Given this list of marker genes Ifi204, Fkbp7, Grina, Pfkp, Xdh, Arnt, Ifi203, Gbp2, Sat1, Napsa, Gba1, Fpr1, H2-T23, C3ar1, Stom, Ifih1, Gbp2b, Nampt, Socs3, Apod, Anxa4, Krt7, Ccl6, Edem2, Ifitm6, Tgoln1, H2-M3, Sgpl1, Lcp1, Tor1aip2, Rnf34, Uck2, Ggps1, Apobec1, Ptprc, C5ar1, Irf7, Lilrb4b, Pnpt1, Nsun4, Ifit3, Cacul1, Ldlr, Gadd45a, Smpdl3a, Cpxm1, Iqgap1, Grn, Lgals3bp, Dhrs7, Ctsh, Mid1ip1, Cxcl2, Hcls1, Gbp7, Egln1, H1f2 (H1.2 linker histone, cluster member), Tgfbi, H2bc4, Prdx5, Itgax, Hes6, Npr3, Tor3a, Ddx3y, Cd72, Lyz2, Ifit2, Rac2, H2ac18, Irf9, Nt5e, Ifi47, Gpc4, Isg20, Ndrg1 (N-myc downstream regulated gene 1), Adgre1, Ube2a, Ch25h, Ccl7, Skap2, Ctsz, Psmb8, Ddit3, Cd300c2, Psmb9 (NCBI Gene Id 16912), Sema7a, Serpinb9, Ube2l6, Abcg1, Csf2ra (colony stimulating factor 2 receptor, alpha, low-affinity (granulocyte-macrophage)), Adar, H2-T24, Cmpk2, Fermt3, Ifi202b, Serping1, Selplg, Hck, Lgmn, Tmem229b, Clec4d, Sgcb, Saa3, Prrx1, Ptpn6, Tgtp1, Msrb1, Tnfsf9, Lst1, Ncf1, H2-D1, Mpeg1, Rab8b, Ncf4, Retreg1, Itgam, Slfn2 (schlafen 2), Hipk3, H2-K1, Ctsb, Chchd10, Abca1, Pcsk5, Npy, Gbp3, Il7r, Isg15, Tmem45a, Mt1 (metallothionein 1), AW112010, Bid, Plac8, Ifi35, Ccr1 (C-C motif chemokine receptor 1), Cd52, Mxi1, Ap3s1, Nckap1l, Evi2a, Igfbp3, Adam8, Daxx, Acsl4, C1qc, Fcgr1, Acp2, Mcoln2, Mbd1, Ccl3, Cfp, Stat1, Ccl9, Bhlhe40, Pcyt1a, Fndc3a, Tbc1d22a, Atp6v1b2, Pdk1, Rtf2, Acod1 (NCBI Gene Id 16365), Gcnt2, Gabpa, Fcgr2b, Cpxm2, Ncf2, Ccl4, Ogn, Uba7, Agrn, B3gnt2, Bnip3l, Trim30a, Usp18, Meox2, Psme2, App, Gmfg, Sp100, Specc1, Vav1, Dnajc5, Nupr1, Iigp1, Gzmd, Tap1, Plekho1, Sphk1, Lyl1 (NCBI Gene Id 17095), H2-Q5, Lmo2, Eif2s3y, Nr1h2, Plin2, Rbbp9, H2-Q4, Mmp3, Tapbp, Itgb2, Pfkl, Sod2, Csnk1d, C2, Ms4a6c, Aldh1a2, Csf1r, Sap30, Igfbp5, Ctse, Cxcl10, Pira1, Lat2, Bcl2a1a, Il18bp, Sprr1a, H2-T10, Procr, Mkrn1, Ak4, Srgn, Sh3bgrl2, Hp, Pla2g7 (NCBI Gene Id 98095), Ccl5, Rab3d (RAB3D, member RAS oncogene family), Mt2, Gatm, Tyrobp, Crabp2, Cyp4v3, Ccl8, Ndrg2, Psmb10, Ifi27l2a, Ero1a, Ift20, Pnp, Fam162a, Cxcl14 (NCBI Gene Id 80491), C1qb, Znfx1, Stab1, Casp4, Glrx, Ifit1, Igtp (NCBI Gene Id 16145), Mmp10, Aldoc, here is a description of the gene set: studied in species Mus musculus from publication Markey MP, Bergseid J, Bosco EE, Stengel K, Xu H, Mayhew CN, Schwemberger SJ, Braden WA, Jiang Y, Babcock GF, Jegga AG, Aronow BJ, Reed MF, Wang JY, Knudsen ES (PMID 17452985) Genes down-regulated in adult fibroblasts with inactivated RB1 by Cre-lox: acute loss of function (LOF) of RB1. Mouse Gene Set: MARKEY_RB1_ACUTE_LOF_DN Functional inactivation of the retinoblastoma tumor suppressor gene product (RB) is a common event in human cancers. Classically, RB functions to constrain cellular proliferation, and loss of RB is proposed to facilitate the hyperplastic proliferation associated with tumorigenesis. To understand the repertoire of regulatory processes governed by RB, two models of RB loss were utilized to perform microarray analysis. In murine embryonic fibroblasts harboring germline loss of RB, there was a striking deregulation of gene expression, wherein distinct biological pathways were altered. Specifically, genes involved in cell cycle control and classically associated with E2F-dependent gene regulation were upregulated via RB loss. In contrast, a program of gene expression associated with immune function and response to pathogens was significantly downregulated with the loss of RB. To determine the specific influence of RB loss during a defined period and without the possibility of developmental compensation as occurs in embryonic fibroblasts, a second system was employed wherein Rb was acutely knocked out in adult fibroblasts. This model confirmed the distinct regulation of cell cycle and immune modulatory genes through RB loss. Analyses of cis-elements supported the hypothesis that the majority of those genes upregulated with RB loss are regulated via the E2F family of transcription factors. In contrast, those genes whose expression was reduced with the loss of RB harbored different promoter elements. Consistent with these analyses, we found that disruption of E2F-binding function of RB was associated with the upregulation of gene expression. In contrast, cells harboring an RB mutant protein (RB-750F) that retains E2F-binding activity, but is specifically deficient in the association with LXCXE-containing proteins, failed to upregulate these same target genes. However, downregulation of genes involved in immune function was readily observed with disruption of the LXCXE-binding function of RB. Thus, these studies demonstrate that RB plays a significant role in both the positive and negative regulations of transcriptional programs and indicate that loss of RB has distinct biological effects related to both cell cycle control and immune function.